Given this list of marker genes KCNN1, NDUFB1, P2RX4 (NCBI Gene Id 5025), SLC9A3, SLC6A20, TPCN1 (two pore segment channel 1), ASIC2, SLC5A6, P2RX3, SLC30A3, CHRNB3, TRPM5, PDE4B, SLC17A5, SLC39A13, GLRX, SLC25A22, SLC24A3 (NCBI Gene Id 96617), ORAI2, SLC25A18, PKD2, DRD2, CHRNA4, ATP13A3, CCT8L2, SLC25A14, OPRM1, KCNQ5, SLC2A10, SLC5A10, HTR3A, GRIN3B, TRPV3, SLC47A2, DPP10, SLC5A7, SLC6A8, CACNA2D1, GRIN2D, SLC8B1, KCNE1, ATP2A1, YWHAE, SLC25A12 (solute carrier family 25 member 12), SLC39A6, NDUFV3, SLC38A5, SLC30A8, CHRNB4, SLC45A4, SLC17A6, TMEM87A, TMEM109, ATP6V0E1, ATP6V0D2, ATP6V1F, ATP5MC3, ATP6V1H, SLC10A5, NPY2R, SLC5A8, CACNA1H (calcium voltage-gated channel subunit alpha1 H), MT-ND6, ATP13A4, KCNIP4, HTR3B, KCNE3, SLC12A8, KCNMB2, PTPN3, KCNQ1, PIEZO1, SLC39A11, SLC13A5, AKT1, KCND2, SEC61A1, CHRNA10, RASA1, KCNN3, SLC13A3, ATP13A2, ITPR3, SLC12A2 (solute carrier family 12 member 2), ANK3, BEST2, SLC4A7, MT-ND5, MT-CYB, ATP12A, TRPM8, ATP8A1, KCNK7, REM1, SLC13A2, CALM1, TMEM165, TRPM7, SLC17A2, SLC12A9, KCNAB1, PKD2L1, CHRNB1, SLC12A1, ATP1A1, RSC1A1, STING1, KCNU1, SLC39A4, ATP1A2, TRPV5, SLC30A6, SLC40A1, KCNJ1, TRPV2, SLC9A6, LRRC26, CALHM3, MRS2, PKD2L2, RRAD (NCBI Gene Id 6236), SLC38A3, SNTA1, CACNB3, ATP6V0D1 (NCBI Gene Id 9114), NDUFB8, CNGB1, GPM6A, TRPA1, SLC9C1, DRD4, SLC38A1, ZACN, CHRNA7, LETM1, SLC39A8, SLC1A1, NNT, SLC23A1, KCNB1, FKBP1A, FGF14, CHRNB2, HCN3, SLC17A3, CACNB2, GRIN3A, SLC18A3, KCNG2, SLC15A4, CACHD1, KCNJ11, SCN2B, PDE4D, ANO10, SCNN1G, ATP5F1E, SLC20A2, TMBIM4, ORAI3, AKAP9, SLC18A2, KCNMB4, SLC6A3, SLC22A1, SLC28A1, KCNN2, AGT, NIPAL2, FXYD2, COX8A, ATP6V1G1, SLC30A2, ATP2C2, GRIN2C, SLC17A7, MCOLN1, KCNF1, KCNH5, FXYD4, NIPAL4, CAV1, TRPC7, SHROOM2, SCN9A, TRPC6, SLC39A2, PCSK9, SLC29A1, SLC38A4, ATP6V1E1, KCNH7, PKD1, GRIN2B, KCNA7, CACNA1S, SLC31A2, CACNA1G, PANX3, CCDC51, ATP6V1B2, SLC17A1, TRPC3, MT-ND1, CLDN16, TUSC3, SLC6A12, SCNN1A, COX4I1, TMCO3, AMIGO1, P2RX5, ASIC4, HCN2, CNGA4, HTR3C, ATP5PB, SLC2A13, ASIC5, ANO9, ATP5PD, KCNMA1, SLC36A1, SLC30A9, PHPT1, ATP5F1C, TRPM3, TRPM2, CACNG5, NIPAL3, KCNS2, SLC24A5, NDUFB5, PIEZO2, KCNJ18, SLC18A1, LRRC55, FXYD7, CABP1, KCNK15, SLC38A2, KCNJ10, KCNE4, GRIA3, ATP2B4, SLC5A3, FKBP1B, ATP2A2, SLC9A9, SCN2A, FGF13, KCNA4, NDUFS8, GRIK4, ATP5F1A, KCNA10, PSEN1, ATP5F1D, SLC1A3, CHRNA9, ATP5MC2, SLC10A4, NDUFV2, KCNA1, ATP1A3, TTYH1, KCNC4, FGF11, SLC10A1, SLC38A7 (solute carrier family 38 member 7), SLC9A2, SLC9C2, SCN1A, CYBB, SLC28A2, UQCRFS1P1, SLC11A2, SLC25A37, TMEM63B, NALCN, NDUFS3, SCN4B, GEM, SLC34A1, ATP5PF, KCNK1, CHRNA5, ATP5MC1, SLC39A9, COMMD1, SNAP25, SLC13A4, TMEM168, NPY, KCNIP1, GRIK3, SLC17A4, NDUFS6 (NADH:ubiquinone oxidoreductase subunit S6), ATP6V1G2, NDUFA12, TRPV4, NDUFA6, PKDREJ, TRPC5, CHRNA6, SLC30A1, KCNG1, HTR3D, MCOLN2, ATP2B2, TRPC4, SLC25A28, ATP5MGL, CACNA1B, SLC16A3, NIPA1, NDUFB7, SLC16A1, ATP6V0A4, PKP2, CALM3, TMEM38A, SLC9A1, YWHAH, NDUFB10, SLC4A4, NDUFA9, HAMP, CNNM2, SLC6A18, PKD1L3, SLC15A3, SLC39A14, SCN10A, CHRNA2, SLC15A2, ATP6V1B1, SLC1A7, DPP6, GRINA, TSPOAP1, SLC1A6, STIM2, ATP6V0B, NDUFS7, ORAI1, SGK1, ATP6V1D, SLC9B1, MT-ND2, SLC6A9, CYC1, SLC39A3, ROMO1, KCNJ16, SLC36A2 (solute carrier family 36 member 2), CACNG1, KCNE5, OTOP1, PRKCB, SLC8A3, KCNC2, ATP6V1C1, CAMK2D, SLC2A9, KCNK17, ATP13A5, FXYD6P3, SLC8A2, OTOP2, SLC8A1, SLC41A2, HPCAL4, KCNQ2, GRIK2, KCNJ9, HVCN1 (NCBI Gene Id 84329), TMEM94, ADRB2, SLC39A10, NDUFA5, CACNA1F, SLC12A4 (NCBI Gene Id 6560), KCNH8, SCN1B, CLCN3, CHRNA3, NALF2, NDUFA8, SLC30A7, CHRNE, SCN3A, ASIC3, NCS1, NRXN2, SLC4A11, CATSPER4, MCUB, CATSPER2, GRIK1, CNGA2, TMEM150C, UCP3, NDUFA10, KCNN4, TRPM4, KCNG3, KCNK6, ENSA, SLC12A3, SLC25A4, SLC5A1, CNNM4, ANO6, CACNG2, TCIRG1, KCNJ8 (potassium inwardly rectifying channel subfamily J member 8), TMEM63C, SLC5A2, SLC5A4, NDUFS2, TMEM38B, NDUFA3, DMAC2L, ATP5PO, CUL5, SCNN1D, TMPRSS3, TRPC1, GHITM, OTOP3, COX7B, SUMO1, SLC39A1, CACNA1D, KCND1, WWP2, TMEM63A, GRIA2, CLCN7, NOX5, MCU, OXSR1, SLC25A5, HCN1, MMGT1, NDUFB3, SLC25A3, TMCO1, SLC23A2 (NCBI Gene Id 9962), SLC12A6, ATP2C1, SLC24A1, KCNJ15, SLC10A3, KCNK18, ATP6V1A, RANGRF, COX5B, TRPM1, ATP6V0A2, SLC6A11, PACSIN3, CHRNA1, UCP2, CALHM1, CACNA1I, KCNQ4, MT-ATP8, CACNB1, KCNT2, SLC4A8, NDUFC1, KCNB2, KCNJ14, CACNA2D4, CHRNG, COX7A2L, CHRND, NDUFA2, SLC24A2, TRPV1, SCN8A, PKD1L1, BNIP1, ATP1B1, SLC1A2, FXYD5, SLC39A7, GRIN2A, SLC47A1, KCNK9, SLC46A1, NOS1, NDUFA4, CACNA2D3, SGK2, SLC5A11, CACNG8, SLC46A3, PRKG1, ABCC9, MT-ND4, ATP4B, ITPR2, FAIM2, TMC1, PKD1L2, KCNV2, CACNG7, KCNJ4 (potassium inwardly rectifying channel subfamily J member 4), SLC36A3, NEDD4, NIPAL1, GRIK5, GRM3, SLC17A8, DLG1 (NCBI Gene Id 1739), NDUFB2 (NCBI Gene Id 4708), SLC39A5, SLC45A2, ATP6V0C, KCNK2, SLC30A10, KCNJ12, TRPV6, TRPC4AP, SLC9A8, SLC45A3, RYR1, RASA3, SLC6A14, SCN7A, SLC25A13, P2RX6, CACNG6, MAGT1, RYR2, HCN4, ATP5F1EP2, KCNK4, SLC13A1, KCNQ3, GPD1L, SCNN1B, KCNMB3, RYR3, SLC28A3, KCNH3, NDUFA7, SLC10A6, SLC5A5, STK39, ATP2B1, COX5A, KCNAB2, KCNK5, ATP6V0E2, MT-CO1, GSTM2, REM2, TSPAN13, SLC29A4, CNGA1, ZDHHC13, KCND3 (potassium voltage-gated channel subfamily D member 3), FLNA, SLC10A2, ITPR1, ATP5F1B, SCN3B, SLC25A27, SLC24A4, NRXN1, NDUFS1, ATP2A3, UNC80, KCNA2, FHL1, KCNH2, MT-ND4L, C8orf44-SGK3, MT-ND3, KCNG4, KCNT1, SLC6A2, NEDD4L (NEDD4 like E3 ubiquitin protein ligase), COX7A1, KCNK10, FXYD3, ATP5MF, CRISP1 (cysteine rich secretory protein 1), MICU3, COX6B1, SLC12A7, ANO1, ATP6V1C2, UQCRFS1, SLC9A7, SLC18B1, KCNH4, MFSD2A, FXYD1, SLC6A15, GRIA1, ATP5MG (ATP synthase membrane subunit g), KCNK13, KCNK3, SLC6A1, SLC34A2 (NCBI Gene Id 153010), MT-CO3, CACNA1A (NCBI Gene Id 773), SLC20A1, STIM1 (NCBI Gene Id 6786), TRPM6, KCNIP2, CACNB4, KCNA3, SLC6A6, SURF1, KCNJ2, NDUFB6, TNNI3, UQCRC1, NALF1, TMEM175, CALHM4, SLC6A5, ATP6V0A1, SCN4A, NDUFB9, SCLT1 (sodium channel and clathrin linker 1), CHP1, GRIN1, KCNA5, KCNMB1, CACNA2D2, KCNS1, GRM2, HTR3E, FXYD6, SLC41A3, CALHM6, P2RX7 (NCBI Gene Id 5027), TMBIM6, ASIC1, SLC9A4, ATP6V1G3, TMEM37, SLC34A3 (solute carrier family 34 member 3), CHRFAM7A, NIPA2, SCN5A, LRRC38, SLC9B2, SLC4A10 (NCBI Gene Id 57282), SLC39A12, P2RX1, KCNJ6, UQCR10, NDUFV1, SLC6A7, KCNAB3, MT-CO2, UCP1, CNGA3, SLC9A5, MTCO2P12, KCNIP3, SLC12A5, CACNG3, CATSPER3 (NCBI Gene Id 347732), PANX1, P2RX2, MICU1, STIMATE, CALM2, SLC45A1, ATP7A (ATPase copper transporting alpha), CATSPER1, CACNA1C, SLC5A12, KCNC3, MCOLN3, SRI, SGK3, KCNE2, CABP2, CTNS, SLC15A1, FGF12 (fibroblast growth factor 12), SCN11A, KCNS3, CNGB3, KCNA6, SLC32A1, CABP4 (calcium binding protein 4, NCBI Gene Id 57010), AMBP, NDUFS5, SLC4A9, SLC6A4, SLC31A1, ANK2, ATP6V1E2, UQCRH, STX1A, KCNK12 (NCBI Gene Id 56660), ITGAV, CABP5, SLC11A1, GPLD1, KCNK16, KCNH6, NDUFS4, ATP13A1, ATP2B3, TMBIM1, SLC30A4, LRRC52, KCNC1, SLC30A5, CACNA1E, ARPP19, ATP1A4, TMC2, CALHM2, NDUFB4, KCNH1, ATP5ME, AQP1, SLC6A13, MT-ATP6, ATP4A, SLC41A1, MICU2, CACNG4 (NCBI Gene Id 84745), CAV3, KCNJ3, NDUFA1, TPCN2, ABCC8, KCNJ13, SLC5A9, NDUFC2 (NCBI Gene Id 4718), KCNV1, KCNJ5, SLC4A5, ATP7B, CALHM5, here is a description of the gene set: Enables the transfer of cation from one side of a membrane to the other. Human Gene Set: GOMF_MONOATOMIC_CATION_TRANSMEMBRANE_TRANSPORTER_ACTIVITY studied in species Homo sapiens